The following is a description of a gene set: Genes upregulated in subsets of cells of a given type within various tumors Human Gene Set: GAVISH_3CA_METAPROGRAM_ENDOTHELIAL_COAGULATION from publication Gavish A, Tyler M, Greenwald AC, Hoefflin R, Simkin D, Tschernichovsky R, Galili Darnell N, Somech E, Barbolin C, Antman T, Kovarsky D, Barrett T, Gonzalez Castro LN, Halder D, Chanoch-Myers R, Laffy J, Mints M, Wider A, Tal R, Spitzer A, Hara T, Raitses-Gurevich M, Stossel C, Golan T, Tirosh A, Suvà ML, Puram SV, Tirosh I (PMID 37258682) species: Homo sapiens In this study, an extensive analysis was conducted to define meta-programs (MPs) capturing intra-tumor heterogeneity across a spectrum of tumor types. The approach utilized non-negative matrix factorization (NMF) to analyze each cell type separately within individual tumor samples. This involved the analysis of malignant cells, macrophages, fibroblasts, endothelial cells, epithelial cells, T-cells, and B-cells. NMF was executed with varying parameter values (K=4, 5, 6, 7, 8, 9), thereby generating 39 programs for each cell type per sample. Each NMF program was summarized by the top genes based on NMF coefficients.\nRobust MPs were then delineated for each cell type using a set of stringent criteria, including recurrence within the same tumor, similarity to programs in other tumors, and non-redundancy within a tumor. Subsequently, these robust NMF programs were clustered (per cell type) based on Jaccard similarity, leading to the identification of MPs associated with each cell type.\nTo enhance the quality of the MPs, a refinement steps were undertaken, involving the removal of MPs suspected of reflecting low-quality data (with an overrepresentation of ribosomal proteins or mitochondrial-encoded genes), single-study inclusion, or similarity to miss-annotated cell types., and this is the list of marker genes: MPZL2, MRPL20, FAM167B, NFIB, PLVAP, DAD1, DDIT4 (DNA damage inducible transcript 4), VCAM1, BGN, IGFBP7, EFEMP1, HTRA1, ARL4A, COTL1, NRP2, PRDX5, CCL14, ACTN1, CALM3, MARCKS, RGCC, FXYD5, TSPO, RPS27L, VWF, FN1, TFF3, TFPI, S100A4, CCN1, SNCG (synuclein gamma), PRCP, TM4SF18, RBP5, CLU, DNASE1L3, CST3, LGALS1, S100A10, MIF, PMP22, AHNAK, SPARCL1, FABP5, LDB2, NUPR1, ADIRF, ANAPC16, MEF2C, QSOX1